The following is a description of a gene set: This event has been computationally inferred from an event that has been demonstrated in another species.<p>The inference is based on the homology mapping from PANTHER. Briefly, reactions for which all involved PhysicalEntities (in input, output and catalyst) have a mapped orthologue/paralogue (for complexes at least 75% of components must have a mapping) are inferred to the other species. electronically inferred by orthology from the curated human pathway studied in species Mus musculus Reactome Pathway: Dectin-1 mediated noncanonical NF-kB signaling part of: CLEC7A (Dectin-1) signaling, and this is the list of marker genes: Ubb, Psma2, Psma3, Psmd1, Nfkb2, Psmd6, Psmd12, Psmc3, Psmb4, Psma5, Psmb5, Psmc5, Psmd13, Relb, Psma4, Psma7, Psmc2, Psmd7, Cul1, Map3k14, Psmb7 (proteasome (prosome, macropain) subunit, beta type 7), Rps27a, Psma6, Psmc6, Psmc1, Psma1, Psmc4, Psmb6